Given this list of marker genes SLIT2, SLIT1, TGFB1I1, SLIT3, LGR6, MYO9B, here is a description of the gene set: Binding to Roundabout (ROBO) receptor, a transmembrane receptor. species: Homo sapiens Human Gene Set: GOMF_ROUNDABOUT_BINDING